Given this list of marker genes TERF1, POLA2, PRIM2, TERF2IP, CTC1, STN1, TINF2, TERF2, ACD, TEN1, POT1, POLA1, PRIM1 (NCBI Gene Id 5557), here is a description of the gene set: DNA polymerases are not capable of de novo DNA synthesis and require synthesis of a primer, usually by a DNA-dependent RNA polymerase (primase) to begin DNA synthesis. In eukaryotic cells, the primer is synthesized by DNA polymerase alpha:primase. First, the DNA primase portion of this complex synthesizes approximately 6-10 nucleotides of RNA primer and then the DNA polymerase portion synthesizes an additional 20 nucleotides of DNA. There have been reports that TRF1 inhibits this activity at telomeres, though the mechanism and physiological relevance of this inhibition remain to be elucidated. Reactome Pathway: Telomere C-strand synthesis initiation species: Homo sapiens part of: Telomere C-strand (Lagging Strand) Synthesis